The following is a description of a gene set: species: Homo sapiens Human Gene Set: MODULE_6 Trachea genes., and this is the list of marker genes: TNC, TPSAB1, ST6GALNAC4, DUSP6, CCL2, LGMN, VSIG4, CHPF, NUPR1, HLF, PTP4A3, PI3, TRPM2, S100A2, SOX10, ALAS2, NOTCH3, AANAT, ST6GAL1, FAM107A, MUC4, PRR4, CLDN3, ECI1, PRSS23, NCALD, SELENOP, MAP2K3, ADH7, PER1, ARHGDIG, SMTN, LIMK2, TNFAIP2, IGFBP3, ACTG2, TTLL12, PROM1, GADD45B, COL6A3, APOD, DBP, ALOX15, TNFAIP3, RSRP1, EPAS1, FZR1, TRIM2, SDC1, GPRC5A, IGHG3, ATF3, APOC4, EGFR, LAMB2, SLPI, RRAD, TNFRSF1B, GOLGA8A, ZMYM3, S100P, LDLR (low density lipoprotein receptor), TPM2, GEM, PRSS8, ATP2A3, RAB31, ZIC2, EPHX1, SLC2A3, FKBP8, TIMP3, KRT14, PCOLCE, CYP4B1, CD14, ALDH1A1, AQP5, ELL2, ALDH3B1, CNKSR1, ARHGEF16, ALDH3A1, TRIM29, SERPINB3, MYLK, HSPA2, GPC3, DUSP5, CLDN5, KRT15, GYG1, PDLIM4, DEPP1, TNFSF10, CNN1, CCL15, TFF1 (NCBI Gene Id 7031), ATP9A, DHRS1, GAGE12F, MYL9, FUCA1, KRT4, SERPINA3, DENND2B (NCBI Gene Id 6764), SPRY1, CMAHP, SEPTIN10P1, CD79A, CX3CL1, AGPAT2, EGR1, CFD, RBPMS, LLGL2, VEGFA, SGCE, CNN3, DDR1, NR1D1, MIA, LTBP1, HMGCS2, SFRP1, LGALS9, CD6, COL2A1, CYB5R1, RNASE1, CD44, TSPAN1, EPCAM, AHDC1, GSTA4, LRP1, HLA-DMA, FMOD (NCBI Gene Id 2331), DTX4, CD151, VWF, ACKR1, CRIM1, PPP1R12B, LAPTM5, CYP1A1, UPK1B, CREB3L1, MAOA, TNFRSF25, LAMA5, CYB5A, MEN1, ARFIP2, TGFB3, RARRES1 (retinoic acid receptor responder 1), MDK, CFB, CYP2B6, NQO1, SLC39A6, ECM2, ITGA6, AQP1, ETS2 (NCBI Gene Id 2114), ACTN1, AQP3, RHOB, DMBT1, SLIT2, SOX9, TPM1, CEACAM6, GPNMB, CDH1, SRRM2, COL1A2, TSPYL2, ABLIM1, FN1, MYH2, PDXK, CD55 (CD55 molecule (Cromer blood group)), NUCB2, IGFBP2, M6PR, KCTD17, GATM, ENG, TMED3, MYL2, FGFR3, GDF15, FCGRT, GPX2, C1S, ITGB5 (integrin subunit beta 5), F3, LYN, KCNN4, ADIRF, LMO4, ANK3, DSP, ITGB4, RBP4, AZGP1, PLEC, GABRP, TGFBI, EFNA1, CDKN1A, AKR1C1, CRABP1, LUM, DDIT4, PTPRN2, EMP3, KRT19, TFF3, FOXJ1, TSPAN3, KRT18, MB, SLC12A2, IGFBP6, HSPG2, CRYAB, CITED2, CD24, HSF1, DGKA, PPL, ALCAM, CFH, CFHR1, CHRNB1, CYP1B1, CCND1, MTUS1, TLE2, CAV1, CSTA, KLK11, SCP2, LDOC1, STAB1, CD22, UGDH, TRIM16 (tripartite motif containing 16), IGHM (NCBI Gene Id 3507), SIX1, CYP2F1, TM4SF1, CXCL8 (C-X-C motif chemokine ligand 8), PIP, CEACAM5, FGFR1, MSLN, TACSTD2, KLF5, AEBP1, RHOD, NHERF1, CXCR4, KDM5C, IGFBP4, TNFRSF10B, RGS1, MSMB, FOSB, PTGDS, CTSC, DEFB1, TFAP2B, FCGBP, JUN, CCL7, AGR2, SPINK2, ASAH1, NNMT, ADGRG6, SERPINA1, UBXN1, DHRS3, TGFBR2, COX7A1, CLDN7, FOSL2, LCN2, ELF3, CLDN10, DDT, CLDN4, SOD3, DNM2, COL9A3, WWTR1, RAC2, PTPRU, GAGE12G, PLPP2 (NCBI Gene Id 8612), GRN, CH25H, ADH1A, KCNQ1, SERPINB5, ERBB3, CPE, MXRA5, S100A4, CRYM, PLIN1, DKK4, GAS1, PTPN13, MVP, HAGH, TSPAN8, KCNMB1, HOXB2, MFAP4, ANXA4, SRGN, STK39, LTF, TNNC2, MAT1A, GPX3, CLEC3B, CCN1, PSCA, PHLDA2, MUC1, ID2B, TNXB, IL4R, KRT5, COL6A1 (collagen type VI alpha 1 chain), PTPRK, S100A11, MAFF, ZYX, TP63, JUNB, NR4A1, PLK3, PDGFRB, WFDC2, BIRC2, KRT7, MAL, TMEM63A, ITPR3, C2, PPP1R15A, GCLC, GNE (NCBI Gene Id 81868), SEC11A, JCHAIN, SERPINH1, ECHS1, CRIP1, FBLN1, PTPRC, DOK1, RARRES2, MUC5B (mucin 5B, oligomeric mucus/gel-forming), ACR (acrosin), S100A9, CD34, CHST1, WDR7, ANXA1, PLA2G2A, IER3 (NCBI Gene Id 91950), TGM2, ST3GAL4, APRT, BMP1, ALDH1A3, CCL5, HLA-DQB1, BCL6, ITGA7 (integrin subunit alpha 7), FBP1, PRB4, CXCL1, CES1, CDC42EP1, IFI27, DPYSL3, S100A8, MGLL, FLNA, NME3, COL6A2, CPD, FABP4, AKR1C3, PLAAT4 (phospholipase A and acyltransferase 4), SERPINB1 (NCBI Gene Id 1992), FBLN2, RNASE4, TCN1, G0S2, ADM, SCGB1A1, FUT6, SYNM, MYH11, HES1, FOS (NCBI Gene Id 2353), SCNN1A